The following is a description of a gene set: Human Gene Set: REACTOME_CHROMOSOME_MAINTENANCE Chromosome Maintenance studied in species Homo sapiens, and this is the list of marker genes: H2BC8, CENPQ, H2BC15, H4C16, CENPL, TINF2, POLD4, GAR1, RTEL1, CENPW, MIS18BP1, H4C6, RFC3, SHQ1, RBBP7, NHP2, PPP6R3, NPM1, PRIM1, POLR2K (RNA polymerase II, I and III subunit K), POLA1, RPA3, ITGB3BP, TERF2IP, RFC1, WRAP53, POLD2, STN1, ACD, H4C13, POLR2C, H2AC7, WRN, KNL1 (NCBI Gene Id 57082), H2BC7, H4C8, H2BC21, H4C9, CENPX, CDK2, POLR2G, NOP10, H2AC20, ANKRD28, POT1, HJURP, H2BC4, H2AZ2, H2BC5, TEN1, H2BC17, RPA2, CENPI, POLR2J, H2AC8, CENPU, CENPS, RUVBL1, H2BC26, CENPK, H3-4, ATRX, OIP5, H2AB1, H2BC14, POLR2L, H2BC11, H2AC18, RFC4, PPP6C, H2BC13, CENPP (centromere protein P), TERF1, RSF1, POLR2D, DSCC1, LIG1, H2BC3, POLR2B, DNA2, POLD1, H2AX, CENPH, CENPA, DKC1, H4C1, SMARCA5 (NCBI Gene Id 8467), POLD3, H2AC14, H3-3A, H4C15, PIF1, H2AJ, POLR2F, CENPC, H4C14, DAXX, RFC5, CENPN, H2BC6 (H2B clustered histone 6), H2BC12L, RBBP4, POLR2I, TERF2, H4C3, POLR2E, CHTF8, FEN1, H2AC19, MIS18A, H4C4, CCNA1, H3-3B, H4C11, H2BC9, H2AC4, H4C2, H2BC10, CCNA2, RFC2, H4C5, CENPO, TERT, CTC1, POLA2, H4C12, H2BC12, BLM, H2BC1, RUVBL2, PCNA, RPA1, CENPT, POLR2A, H2AC6, PRIM2, CHTF18, CENPM, POLR2H